Given this list of marker genes H2AC20, UBB, H2AB1, EP300, H2AC8, ATP2A1 (ATPase sarcoplasmic/endoplasmic reticulum Ca2+ transporting 1), HDAC10, H3C6, MIR34C, SIRT6, STAT1, NCSTN, HDAC11, MIB1, CREB1, ADAM17, H4C3, PSMD14, PSMD13, ELF3, H4C12, NOTCH2, PTCRA, TACC3, H2BC7 (NCBI Gene Id 8343), PSMA7, B4GALT1, H2BC6, H3C4, FBXW7, APH1B, PSMC5, YBX1, H3-3A, SEM1, TNRC6B, ELANE, HDAC5, H4C4, NOTCH2NLC, GZMB, H2BC14, MIR34B, APH1A, AGO4, ACTA2, PLXND1, NOTCH2NLB, RUNX1, AGO2, TLE3, NOTCH2NLR, JUN, TNRC6A, PSMD3, H2BC17, HEY2, ATP2A3, HDAC7, H2BC12, TMED2, H4C1, HDAC6, HDAC9, H4C13, HES5, NBEA, H2BC15, HES1, AKT1, UBC, H3C12 (NCBI Gene Id 8356), MIR449B, H3C10, PSEN1, PSMC4, TNRC6C, PSMA3, TLE2, SKP1, H2BC5 (H2B clustered histone 5), PSMB4, H2BC3, MIR449C, PSMD1, HDAC3, NOTCH4, E2F1, H2BC26 (H2B clustered histone 26), PSEN2, HDAC1, PSMB3, H2AZ2, WWP2, MOV10, POGLUT1, AGO3, H2BC21, PSMB1, MAML1, H2AC18, PRKCI, NCOR1, MFNG, H3C8 (NCBI Gene Id 8355), RBX1, H3-3B, CUL1, H2AJ, PSMC1, CREBBP, PSMB2, H4C8, PSMC6, MIB2, H2BC4, ST3GAL4, FCER2, JAG1, RPS27A (NCBI Gene Id 6233), H4C14, DLGAP5 (DLG associated protein 5), H3C11, PSMC3, H2BC12L, MAML3, HEYL (hes related family bHLH transcription factor with YRPW motif like), FLT4, E2F3, H4C6, H3C7, NOTCH2NLA, SNW1, MIR449A, ITCH, NOTCH1, PSMB7 (proteasome 20S subunit beta 7), SMAD3, PSMB6, YWHAZ, H2AC14, HEY1, H3C1, PSMA4, WWC1, DNER, RAB6A (NCBI Gene Id 5870), EGFR, H3C14, PSMA1, PSMD7, MIR200C, TFDP2, H2AC19, ST3GAL6, DLL4, MAMLD1 (mastermind like domain containing 1), HIF1A, HDAC4, PSMD6, MAML2, CCNC, H2BC13, DTX4, H2AC4, ADAM10, H3C13, PSMB5, TLE1, PSMD2, EGF, NEURL1B, MDK, TLE4, MIR200B, NUMB, MIR206, H2AX, MYC, PSMA6, POFUT1, H4C15, DLL1, ARRB1, MIR150, NCOR2, LFNG, H3C3, PBX1, TBL1XR1, TP53, PSMA2, H4C5, KAT2B, CDK8, CNTN1, SEL1L, ARRB2, H2BC8, H2AC7, ADRM1, CCND1, H2AC6, PSMC2, PSMD8, PSMD12, H2BC9, H3C15, KAT2A, H2BC10, RBPJ, TBL1X, HDAC2, MIR302A, PSMA5, IKZF1, ATP2A2, FURIN, H4C16, H4C2, H4C11, RFNG (RFNG O-fucosylpeptide 3-beta-N-acetylglucosaminyltransferase), UBA52, ST3GAL3, H3C2, NOTCH3, PSMD11, DTX2, H4C9, FABP7, DLK1, TFDP1, AGO1, HDAC8, DTX1, H2BC11, JAG2, H2BC1, NEURL1, MIR181C, PSENEN, here is a description of the gene set: Signaling by NOTCH studied in species Homo sapiens Human Gene Set: REACTOME_SIGNALING_BY_NOTCH